Given this list of marker genes CORO1C, ITGB1, RAC1 (Rac family small GTPase 1), CLN3, DMTN, AQP1, APPL2, FGF2, TGFB1, WDPCP, PRR5L, AKAP12, MIR19A, CYGB, FER, ITGB1BP1, NHERF1, PAK1, RCC2, AKT1, DDR2, MTA2, ZEB2, GNA12, HYAL2, RFFL, PRKCE, BRAF, HAS1, ITGB3, MIR19B1, ARHGAP4, BAG4, MACIR, ARHGEF7, ACTA2, APPL1, GNA13, THBS1, PTK2, MIR145, SDC4, here is a description of the gene set: Human Gene Set: GOBP_REGULATION_OF_FIBROBLAST_MIGRATION studied in species Homo sapiens Any process that modulates the rate, frequency or extent of fibroblast cell migration. Fibroblast cell migration is accomplished by extension and retraction of a pseudopodium.